Given this list of marker genes LY96 (NCBI Gene Id 23643), CD14, TLR4, FADD, RIPK3, RIPK1, TICAM1, CASP8, TICAM2, here is a description of the gene set: part of: TRIF (TICAM1)-mediated TLR4 signaling  species: Homo sapiens Reactome Pathway: TRIF-mediated programmed cell death TLR3 and -4 trigger TRIF-dependent programmed cell death in various human and mouse cells (Kalai M et al. 2002; Han KJ et al. 2004; Kaiser WJ and Offermann MK 2005; Estornes Y et al. 2012; He S et al. 2011). Apoptosis is a prevalent form of programmed cell death and is mediated by the activation of a set of caspases. In addition to apoptosis, TLR3/TLR4 activation induces RIP3-dependent necroptosis. These two programmed cell-death pathways may suppress each other. When the caspase activity is impaired or inhibited, certain cell types switch the apoptotic death program to necroptosis in response to various stimuli (TNF, Fas, viral infection and other stress stimuli) (Kalai M et al. 2002; Weber A et al. 2010; Feoktistova M et al. 2011, Tenev et al 2011).